Given this list of marker genes KRTAP19-3, ITGB3, P2RY14, B4GALT7, HMGCS2, MRPL37, HIBCH, SPSB4, KLF10, HNRNPDL, EPPIN, APLP1, HERPUD1, MRPS14, RAB27A, TBX5, ACP5, GNL3, KCNIP1, CD36, DSCAML1, VMP1, TUBGCP4, PACS2, BMP8B, PPIB (NCBI Gene Id 5479), IPO5, IL6ST, TMEM14C, CCR1, CDC42SE1, RBM4B, MTCH2, PRMT6, NR4A3, DNMT3L (NCBI Gene Id 29947), NLGN1, GRINA, SAA1, UROS, DTX2, SPINT2, NDUFA12, POLR2E, PSMC1, CD70, CAPN15, SMYD1, KCNMA1, VIPR2, KRT79, PCP4, NAGA, ZNF358, TNNT1, SPSB2, GTF2H4, TRPC3 (transient receptor potential cation channel subfamily C member 3), CRNKL1, HMGB1, NIP7, RNF181, TPTE, UBIAD1, ATOSB, PADI2, FGB, IKBKG, MORF4L1, SENP3, KRT72, AP3M2, FAM210B, C8orf82, MFN2, SDC1, CCR5 (C-C motif chemokine receptor 5), P2RY1, DAPP1, ASGR2 (asialoglycoprotein receptor 2), TTC8, OGT, C19orf53, FKBP11, WIPI1, ARHGEF3, UNC13A, NINJ1, ATP5PF, PRKAB1, AKR1E2, DDX42, MRPS6 (NCBI Gene Id 64968), CSF1R, FSHB, PPP4R1, RAB6A, DENND11, TRAK1, PAFAH2, CDC42BPA, NKX2-3, RPS16, CPB1, SMO, XPNPEP1, ATCAY, IRAK1BP1 (interleukin 1 receptor associated kinase 1 binding protein 1), TDP2 (tyrosyl-DNA phosphodiesterase 2), CNPY2, SEPTIN4, ZNF394, PCNX3, GFER, ERP44, FUCA1, PHF19, CXCL16, IL1R2, DENND4B, TASOR2, TLR6, ZBTB7B, MFAP3, LHCGR, CTSH, SHROOM3, IKBKE, GGPS1, RGS9, KCND3, BRAP, POLL, COL13A1, EGFL8, CD109, AMIGO1, MMP1, DPYS, LIN9, PLP1, HEMK1, NANP, PARD6G, TMEM30B, SYNE4 (spectrin repeat containing nuclear envelope family member 4), CTDNEP1, BRMS1 (NCBI Gene Id 25855), DEPDC7, SAMSN1, PTGIR, CYP4A11, NCBP2AS2, CHST2, EMC8, SIN3A, NTNG1, CACNA1A, PEX7, ACOT1, COL6A1, NOTUM, NFKBIL1, SDF2L1, CEBPA, CLIP1, CSF3R, ZNF841, MVK, ST6GALNAC6, GPR137B, HLA-DMA, DNM1L, NAA38 (NCBI Gene Id 84316), LUM, MRPL33, PFN1, CD68, NRL, DSPP, RNF185, FSCN1, C2orf76, PRADC1, HNRNPU, SLC25A39, PTPRR, EFNB1, CEP20, CDH2, GARS1, ATXN7L3, CIMIP2A, SARAF, EEF1B2, CD33, ICOSLG, P2RX7, NECAP1, EBI3, here is a description of the gene set: mouse primary BMDCs were stimulated with tlr ligands and gene expression changes were profiled on Affymetrix arrays species: Homo sapiens Human Gene Set: GSE17721_LPS_VS_CPG_2H_BMDC_DN from publication Amit I, Garber M, Chevrier N, Leite AP, Donner Y, Eisenhaure T, Guttman M, Grenier JK, Li W, Zuk O, Schubert LA, Birditt B, Shay T, Goren A, Zhang X, Smith Z, Deering R, McDonald RC, Cabili M, Bernstein BE, Rinn JL, Meissner A, Root DE, Hacohen N, Regev A (PMID 19729616) Genes down-regulated in comparison of dendritic cells (DC) stimulated with LPS (TLR4 agonist) at 2 h versus DC cells stimulated with CpG DNA (TLR9 agonist) at 2 h.